The following is a description of a gene set: Human Gene Set: GSE26669_CTRL_VS_COSTIM_BLOCK_MLR_CD8_TCELL_UP To elucidate the gene expression “footprint” of antigenically challenged T-cells which had been treated with anti-LFA-1, CTLA4Ig, anti-CD40-ligand antibodies, we performed microarray gene expression analysis comparing the expression profile of costimulatory blockade treated and untreated responder T-cells. from publication Pearl JI, Lee AS, Leveson-Gower DB, Sun N, Ghosh Z, Lan F, Ransohoff J, Negrin RS, Davis MM, Wu JC (PMID 21362570) Genes up-regulated in comparison of untreated CD8 T cells versus CD8 T cells treated with leukocyte costimulatory blockade antibodies. studied in species Homo sapiens, and this is the list of marker genes: RNF19B, POLR1E, ZBTB32, NPC2, KIF18B, KCNH3, EIF3C, PSMB4, NDUFB6, ANKLE1 (NCBI Gene Id 126549), EPSTI1, ZNF207, MN1, KDELR1, PGD, TREML2, NMI, TPI1, MOV10, HACD3, HMGCR, ELANE (NCBI Gene Id 6417, elastase, neutrophil expressed), TFB1M, CD86, NABP1, IFITM3, NSA2, OTULIN, NCOA7, E2F8, IFITM2, EMC2, EIF3J, PAM16, VMP1, ELMO2, AK2, SSR4 (signal sequence receptor subunit 4), LMAN1, CKAP2L, ELAVL2, EBNA1BP2, TACC3, SERPINB9, ZNF593, ACOT11, IFI44L, OCEL1, OSBPL3, SNRPC (NCBI Gene Id 6631), CUTA, APEX1, PSMA2 (proteasome 20S subunit alpha 2, NCBI Gene Id 5683), VMA21, CDCA2, MVP, GNPNAT1, PHGDH, TAPBP, ATXN7L1, CHMP5, MCTS1, PPP3CC, COMMD7, LTA, AQP9, PHLDA3, KRT10, HSD17B7, NME1, RBM14, C8orf33, NEK2, GPC1, CDK4, DUT, NAA38, ENOPH1, TYW1, GATAD1, CD5, ADAMDEC1, CDC7, CCT6A, SH3BGRL, DDIAS, RNF114, CHCHD1, RBIS, GALK1 (galactokinase 1), ACADVL, ASF1B, PDSS1, CCDC157, HNRNPLL, NME2, TNFSF11, ADGRG3, CCNA2, LSM4, ZNF524, NDUFA6, FARSA, TNFRSF9, PSMA4, PGM5, RSAD2 (radical S-adenosyl methionine domain containing 2), S100A8, MRPL35, IL15, MRPL48, SLC25A13, TCP1 (NCBI Gene Id 6950), KBTBD11, SLC16A5, CCN3, EIF5A, RGS1, UBE2L3, MRPS33, SRA1, ZSCAN22, MRPS28, RBL1, MED24, TAP2, RFC5, LSM2, EEF1E1, LGALS1, IL2RA, RABEPK, CFDP1, CST8, TOMM7, CYP11A1, ATP5IF1, PRDX4, NDUFC1, CALR, PSMA5, PLXDC2, NUAK2, TSPAN9, VIM, RBMXL1, HARS1, GSTO1, RPL7L1 (ribosomal protein L7 like 1), CXCL6, LEO1, SRP14, COPS5, LGALS9B, RSRC1, PTGES2 (prostaglandin E synthase 2), HPRT1, TARS1, RAD51AP1, TIAM1, H2BC5, UBXN2A, GPT, ERCC6L, FEN1, PPIH, TIMM22, MTX2, GTF2F2, FNTB, CPT1C, FASTKD2, TFDP1, THYN1, ALG14, LYNX1, ATIC (NCBI Gene Id 471), MTHFD1, DYNLL1, NUDCD2, HERC6, BID, EIF2S1, PFDN1, CASP7, TCF19, IDI1, PPP6C, CNP, NOL7, TKT, FAM98C, PNO1, ECE1, PEX2, DDN, CHAF1B (chromatin assembly factor 1 subunit B), BCAP29, MRPL39, LANCL2